Given this list of marker genes PPIL1, CC2D2A, WNT1, TBC1D23, IFT140, RPL10 (NCBI Gene Id 88324), TRA2B, MKS1, CDK20, MFSD2A, CTNNB1, TUBB2B, EN1, MEGF8, PRICKLE1, RNF112, TTBK2, MED12, CDC40, EN2, here is a description of the gene set: Human Gene Set: GOBP_EMBRYONIC_BRAIN_DEVELOPMENT species: Homo sapiens The process occurring during the embryonic phase whose specific outcome is the progression of the brain over time, from its formation to the mature structure.